Given this list of marker genes WAS, ARPC1A, BTK, ARPC5, NCKIPSD, ARPC2, ABL1, ABI1, MAPK3, ARPC4, WASF3, MAPK1, WASF2, BAIAP2, ACTB, PTK2, NCK1, GRB2, WIPF2, CDC42 (cell division cycle 42), ARPC1B, ARPC3, NCKAP1, RAC1, WASF1, ACTG1, CYFIP1, ACTR3, ACTR2, WIPF3, BRK1, ABI2, WASL, NCKAP1L, CYFIP2, WIPF1 (WAS/WASL interacting protein family member 1), here is a description of the gene set: RHO GTPases Activate WASPs and WAVEs species: Homo sapiens Human Gene Set: REACTOME_RHO_GTPASES_ACTIVATE_WASPS_AND_WAVES